The following is a description of a gene set: from publication Hill JA, Hall JA, Sun CM, Cai Q, Ghyselinck N, Chambon P, Belkaid Y, Mathis D, Benoist C (PMID 19006694) CD4(+)Foxp3(+) regulatory T (Treg) cells originate primarily from thymic differentiation, but conversion of mature T lymphocytes to Foxp3 positivity can be elicited by several means, including in vitro activation in the presence of TGF-beta. Retinoic acid (RA) increases TGF-beta-induced expression of Foxp3, through unknown molecular mechanisms. We showed here that, rather than enhancing TGF-beta signaling directly in naive CD4(+) T cells, RA negatively regulated an accompanying population of CD4(+) T cells with a CD44(hi) memory and effector phenotype. These memory cells actively inhibited the TGF-beta-induced conversion of naive CD4(+) T cells through the synthesis of a set of cytokines (IL-4, IL-21, IFN-gamma) whose expression was coordinately curtailed by RA. This indirect effect was evident in vivo and required the expression of the RA receptor alpha. Thus, cytokine-producing CD44(hi) cells actively restrain TGF-beta-mediated Foxp3 expression in naive T cells, and this balance can be shifted or fine-tuned by RA. species: Homo sapiens Human Gene Set: GSE13306_TREG_VS_TCONV_LAMINA_PROPRIA_UP Genes up-regulated in comparison of regulatory T cell (Treg) versus conventional T cells activated with lamina propria dendritic cells., and this is the list of marker genes: PSD, PAPPA2, MAB21L3, ACER2, YPEL2, BPIFA1 (BPI fold containing family A member 1), JARID2, CREBL2, PER3, CBX7, ALDH1A2, GPR174, ABCB11 (ATP binding cassette subfamily B member 11), TRIM46, SLC25A36, SSH1, TIAM1, SPRED1, SBSN, DCXR, NFAT5, EBI3, CAMSAP2, LTF, CLTB, QNG1, HLA-DOB, RHOB, NEK5, PCYT1A, HIPK2, PPP1R3C, IFNAR1, HUWE1, DSG1, PIM1, RABGAP1L, FES, PSD3, SHISA2, GPLD1, INPP4B, SMOX, PARP8, DLG3, LRP11, PTPN11, DNMT3A, STOML3, KLF4, PARD6G, BCAS1, ST3GAL2, GPR83, CASD1, KPLCE, EFNA5, STXBP6, NECAP1, MPP1, MMP15, KLRC2, NOSTRIN, HLA-A, ARF4, FAM199X, RAP1GDS1, SLC22A2, CNKSR3, DIO2, KIAA1217, CCDC198, BEND5, B4GALT4, PPM1B, LRRN4 (NCBI Gene Id 164312), CAPN5, ARF3, TNFAIP2, GLIS2, RGS1, ARMCX4, IZUMO1R, ZNF768, GNAQ, DHRS3, TOB1, SPRY1, RBP1, GIMAP8, TMEM38A, RTL6, KRT76, UAP1, NPC1, SGK1, RAB27A, TRAF4, SORCS2, PDGFB, OPTC, IFT56, UNC13B, PRKAR1B, REP15, CPNE3, UBXN1, EPHX4, PON3, TUBB2B, RILPL2, LTB, PBLD, MUC13, NLRP3, EMC7, ZDHHC24, SLC23A3, GIMAP5 (GTPase, IMAP family member 5), SAMD14, CDHR3, TRIB1, TBCA, PBX2, PLEKHB2, RNF121, GNS, CCS, TRAT1, CD37, RABGAP1, NRROS, PPIB, BHLHE40, PARK7, DNAJB14 (NCBI Gene Id 79982), MANSC1, KIAA0513, MKNK2, RAPSN, TRIM63, CYP11A1, MEST, FIS1, CYBA, NUCB2, ILVBL, PDCD1LG2, IKZF4, ADAMTS6, C1QTNF2, TEK, NDRG2, DISP1, NIBAN1, DOCK10, TNFSF10, ICOSLG, PLD4, ADAMTS1, PTPN1, TSEN15, LGMN, SLC19A2, SLC44A1, ZDHHC15, IL10RA, PRNP, CCDC171, EXTL3, QKI, LMO7, TDRD5, TM7SF3, PLAGL1, C9orf78, MEA1, AGPAT2, ODC1, ST7, PLPP2, ZNF229, LPCAT1, SEC22A, MGAT1, SNX18, DNAJB2, APEH, VAV2, RBM48, NRN1, ATXN2 (NCBI Gene Id 8095), TRIM11, SIL1, ZKSCAN3, MAGED2, IL10RB, PLA2G12A, ARL3, NFKBIA